Given this list of marker genes Vcam1, Cd40, Klhl25, Sox15, Ephb2, Tnfsf13, Nfkbiz, Cd86, Il15ra, Brd7, Timd5, Coro1a, Bloc1s3, Irs2, H2-T23, Efnb2, Bad, Rps6ka1, Zfp335, Il33, Card11, Igf2, Il6, H2-Oa, Gata3, Il4, Tgfbr2, Btnl2, Il7, H2-Ea, Tacr1, Ptprc, Nck1, Stat5a, Tnfsf4, Gp1bb, Pms2, Lgals8, Cd59a, Sox13, Slc4a1, Il12b, Cd81, Bloc1s6, Hmgb1, Itpkb (NCBI Gene Id 68660), Stap1, Il36b, Smarce1, Wnt5a, Tslp, Cyld, Blm (NCBI Gene Id 12144), Il1b, Adam8, Acta2, Runx1, Vav3, Il2 (interleukin 2), Msh2, Prkcq, Tcf3, Il12a, Tac1, Bmi1, Gpr183, Cd274, Prkcz, Ephb6, Tlr4, Shld1, Cd74, Cd276, Selp, Pycard (NCBI Gene Id 66824), Kars1, Crlf2, Lilrb4a, Ddr2, Chrnb2 (NCBI Gene Id 11444), Abl2, Btn2a2, Nectin2, Cd3e, Il10, Abl1, Ambra1, Mef2c, Mir326, Exosc6, Lgals9, Kmt5c, Mad2l2, Hes1, Ap3d1, Actb, Fcho1, Ulbp1, Lgals1, Atp11c, Cd320, Tlr9, Opa1, Kitl, Ihh, Hsp90aa1, Il15, Cd80, Pagr1a, Il1a, Il4i1 (NCBI Gene Id 15088), Zbtb1, Sh3kbp1, Csf1r (colony stimulating factor 1 receptor), Cd47, Fgfr1, Rhoh, H2-M3, Tespa1, Il16, Capn3, Mdk, Pcid2, Tgfb1, Wnt3a, Ep300, Gp9, Ccl2, Sash3 (SAM and SH3 domain containing 3), Il4ra, Arid1a, Gp5, Smarcd2, H2-Eb2, Plpp6, Tafa3, Zap70, Rasgrp1 (RAS guanyl releasing protein 1), Zmiz1, Dhps, Cd40lg, Zfp609, Vav1, Selenok, Peli1, Ccl5, H2-DMb1, Nkap, Slamf1, Rhoa, Klrk1, Gpam, Sart1, Ctsc, Il12rb1, Skint1, Hps1, Pnp, Vtcn1 (V-set domain containing T cell activation inhibitor 1), Sirpa, H2-DMa, Fgf10, Brd2, Pik3r6, Sphk2, Cd209e, Il6st, Nfatc2, Socs1, Gli3, Irgm1, Fadd, Flt3l, Mif, Pdpn, Efnb3, Ighd, Nod2, Exosc3, Ppp2r3c, Lilra5, Prlr, Ager, Tnf, Anxa1, Rps3, Socs5, Bcl10, Jund, Atad5 (ATPase family, AAA domain containing 5), Cd1d1, Ccr7, Arid2, Nr4a3, Myd88, Vsir, Timd2, Nsd2, Tnfsf9, Tnfsf13b, Kat5, Rag1, Mpl, Aif1, Ccr2, B2m, Shld3, Il13, Clec4d, Ccl19, Ccdc88b, Myb, Ada, Cd226, Flot2 (flotillin 2), Il7r, Cd4, Il1rl2, Cdkn1a, Hsph1, Gimap5, Axl, Ighm, Lep, Smo, Hspd1, Ccl21a, Gp1ba, Dock8, Tbx21, Pck1, Tyrobp, Timd6, Xcl1, Ywhag, Dusp10, Nckap1l, Ttbk1, Smarcb1, Tnfrsf13c, Mmp8, Tnfrsf4, Mlh1, Clec7a, Phf10, Btk, Ticam1, Kcnn4, Fbxo38, Igfbp2, Ifng, Nr5a2, Tirap, Stat6, Dgat1, Gimap3, H2-Ob, Cd209d, Kmt5b, Lbp (lipopolysaccharide binding protein), Cftr, Cd55b, Cyrib, Lef1, Egr3, Smarca4, Tfrc, Trem2 (NCBI Gene Id 83433), Klhl22, Plek, Sox4, Pdcd1lg2, Lrrk2, Cd1d2, Cd300lb, Tnfsf14, Ptpn22, Rara, Il18, Brd4, Cd5, Paxip1, Slc39a10, Flna, Havcr1, Zp3, Hlx, Foxp3, Hamp, H2-Aa, Il5, Nck2, Lilrb4b, Ccn2, Il3, Tyk2, Smarcc1, Cd209c, Mmp14, Il1rl1, Foxo3, Thbs1, Pbrm1, Shb, Il2ra, Cd38, Cd55, Smarcd1 (NCBI Gene Id 83797), Smarcc2, Malt1, Efnb1, Spn, Cd6, Jak3, Ptprj, Nfkbid, Prkaa1, Hmces, Tox, Inpp5d, Bcl2 (B cell leukemia/lymphoma 2), Cebpa, Cd160 (NCBI Gene Id 99838), Shld2 (NCBI Gene Id 75698), Pla2g4a, Syk, Shh, H2-Eb1, Raet1d, Itgal, H2-DMb2, Dppa1, Rasal3, Ap3b1, Carmil2, Havcr2 (hepatitis A virus cellular receptor 2), Dpp4, Pdgfb, Spi1, Cd27, Sox12, Tnip2, Lyst, Gas6, Zbtb7b, Icos, Tnfrsf14 (NCBI Gene Id 230979), Slc7a1, Thy1, Prkdc, Actl6b, Trp53bp1, Svep1, Runx3, H2-Ab1, Rif1, Actl6a, Ddrgk1, Cbfb, Il23a, Traf6, Igf1, Smarcd3, Akirin2, Irf1, Cd59b, Pear1, Spta1, Ripk2, Smarca2, Ephb4, Vnn1, Lck, Cd244a, Stat5b, Il21, Xrcc6, Il2rg, Clcf1, Wnt10b, Icosl, Cd24a, Nlrp3, Tnfsf11, Ppp3ca, Adk, Cd46, Pdgfrb, Cav1, Xbp1, Jak2 (NCBI Gene Id 98155), Epo, Dnaja3, Tlr6 (NCBI Gene Id 21899, toll-like receptor 6), Cd28, Cd83, Bst1, Bcl6, here is a description of the gene set: Any process that activates or increases the frequency, rate or extent of activation. species: Mus musculus Mouse Gene Set: GOBP_POSITIVE_REGULATION_OF_CELL_ACTIVATION